The following is a description of a gene set: Human Gene Set: AREB6_04 Genes having at least one occurrence of the motif CBGTTTSNN in the regions spanning 4 kb centered on their transcription starting sites. This matches the TCF8 transcription factor binding site V$AREB6_04 (v7.4 TRANSFAC). species: Homo sapiens, and this is the list of marker genes: SERTAD4, MIDEAS, KCNJ2, KLHL17, PDE3B, PCBP4, SEPTIN4, BCL9L, FSIP2, NEUROG1, SLCO2A1, OTUD7B, RFX5 (regulatory factor X5), FERRY3, HOXA11, MAGOHB, IL7R, NACA4P, ELAVL4, HOXA6, COLCA1, CIITA, PABPC5, HNRNPUL1, RNF24, OTX2, APOLD1, SLC44A1, FES, PLAGL2, ARF6, TSGA10, MRPL51, PLEC, SLC30A3, FCHSD2, EBF2, CHST1, HOXA2, NUP98, PPP1R1B, CDC37L1, DDX17, CLMP, KRT83, MEIS2, DCLK2, LAG3, ASPN, M6PR, ARPP19, ESPNL, TFCP2L1, LINC00905, RACK1, PXN, FOXA1, OMG, MAFB, ELOVL6, GEMIN4, NAV3, FBLN5, VPS26A, FOXN3, PPP1R9B, PRDM1, PTGR3, TRAF3IP3 (TRAF3 interacting protein 3), DMD, TAGLN2, WNT4, ZNF503, SKIDA1, CWF19L2, HTR2C, GOLM2, MXI1, TGIF1, ZEB2, LST1, TRERF1, STAT6, BDNF, RASGRF1, SLC7A11, ITGBL1, HMGB1, LINC02687, OLFML3, BRMS1L, BMF, H2AZ2, GART, NEDD9, ARMC8, TNFRSF17, DENND2B, NMNAT2, IGF1R, ERG, TRPS1, NFATC4, FEZF2, HIP1R, NFIX (NCBI Gene Id 4784), ZC3H11A, TJP1, PDZRN4, XPO1, ESRRG, ATP1B4, SYT16, WNT2, RAB35 (NCBI Gene Id 11021), PATL1, SOX10, POFUT1, FAM180A, CYTIP, RORA, SWAP70 (switching B cell complex subunit SWAP70), SON, TRIM14, BCL11A, AGBL5, JADE2, FOXA2, MMRN1, LGI2, PKP4, CMKLR1, SOSTDC1, EFNA1, FUT8, FGF9, ATOH8, JUNB, MAP1A, IRX5, HEXIM2, NDST4, SLA2, POU4F1, NOL4L, HOXC10, OXSM, PCF11, KDM3A (NCBI Gene Id 55818), LMOD1 (NCBI Gene Id 25802), EFNB2, PCYT2, AKT2, PURG, SLN, NXF3, OTP, EDN1, CHD6, ITIH2, HPCAL1, FAP, KLF5, KCNK5 (NCBI Gene Id 8645), WRN, SMARCA2, ROM1, ATP8B3, SLC25A23, SPART, ZNF436, TAFA1, EML3, BMP4, RAD51AP1, HSPB2, NF1, HIVEP3, DEF6, GABRQ, SOX4, SH2B3, PAN3, ZNF521, VAMP4, PCDH7, LMO4, CCDC91, CRYAB, HNF4A, LRRN3, RUBCNL, JAKMIP2, CCN2, PCGF5, ANKRD22, EIF4G1, SHC3, H1-2, STAG2 (NCBI Gene Id 10735), GNB4, LRRC8A, KLF12, PIK3R3, FGF13 (NCBI Gene Id 730528), VAX1, STX5, LTBP1, SNAP25, DLG2, CDKN2C, PURB, MAPK3, CCDC148, CADM2, HR, PSMA1, KLF7, SOX11, CLEC7A, LINC01138, CLIC1, LTA, NFKB1, ME1, FZD1, NACA2, WDPCP, FLRT1, FOXP2, PRKAG1, TCF4, NRK, KMT2A, WNT2B, MSH5, NOC2L, PDCD4, PHEX, RHBDL3, GATA6, COL8A1, NR6A1, DUSP6, NIPBL, SDK2, TMC5, PPP3CB, ERBB3, WBP2NL, NDUFA4L2, TFAP2D, SRSF2